The following is a description of a gene set: Mouse Gene Set: GOBP_RESPONSE_TO_VITAMIN species: Mus musculus Any process that results in a change in state or activity of a cell or an organism (in terms of movement, secretion, enzyme production, gene expression, etc.) as a result of a vitamin stimulus., and this is the list of marker genes: Becn1, Lep, Snai2, Bmp7, Lipa, Mdm2 (transformed mouse 3T3 cell double minute 2), Trim24, Snw1, Scap, Kl, Med1, Kank2, Egfr, Rela, Stc1, Rxrb, Nfkbiz, Hlcs, Ascl1, Tspo, Gpx1, Bglap, Ppard, Pdia3, Lrat, Ptgs2, Casr, Aldh1a2, Tpcn2, Brip1, Tyr, Enpp1, Dnmt3a, Kdm6a, Gstp1, Spp1, Map1b, Stc2, Otc, Pemt, Gas6, Il1a, Alad, Trim25, Serpina7, Bglap2, Rbp1, Vdr, Eif2ak2, Col1a1, Postn, Sod2, Phex, Ada, Gdap1, Lrp6, Ogg1, F5, Kynu, Cat, Tnc, Sfrp1, Fabp1, Fkbp1b, Srsf2, Rara, Cyp26b1, Tyms, mt-Cytb, Pim1, Mn1, Folr2, Cdkn2d, Folr1, Epo, Gstt1, Cyp27b1, Gprin3, Prkcb, Fgf23 (NCBI Gene Id 64654), Cbs (cystathionine beta-synthase), Cyp24a1, Alpl, F7, Abca1, Abcb1a, Penk, Tgfb1, Itga2, Bche, Cyp1a1, Pdx1, Bglap3, Rxra, Pitx2, Fes, Ccl2